The following is a description of a gene set: Human Gene Set: GSE25123_CTRL_VS_IL4_AND_ROSIGLITAZONE_STIM_MACROPHAGE_DN from publication Szanto A, Balint BL, Nagy ZS, Barta E, Dezso B, Pap A, Szeles L, Poliska S, Oros M, Evans RM, Barak Y, Schwabe J, Nagy L (PMID 21093321) Conditional macrophage-specific PPARg knockout mice were generated on C57Bl/6 background by breeding PPARg fl/- (one allele is floxed, the other is null) and lysozyme Cre transgenic mice. PPARg and IL-4 signaling was analyzed on bone marrow-derived macrophages. Bone marrow of 3 mice per group was isolated and differentiated to macrophages with M-CSF (20 ng/ml). 20 ng/ml IL-4 was used to induce alternative macrophage activation and 1 uM Rosiglitazone (RSG) was used to activate PPARg. From each mouse 4 samples were generated: 1. M-CSF, 2. M-CSF+RSG, 3. IL-4 and 4. IL-4+RSG. All compounds were added throughout the whole differentiation process, and fresh media was added every other day. Control cells were treated with vehicle (DMSO:ethanol). After 10 days, RNA was isolated and gene expression profiles were analyzed using Mouse Genome 430 2.0 microarrays from Affymetrix. Genes down-regulated in wildtype bone marrow-derived macrophages: control versus IL4 and rosiglitazone. studied in species Homo sapiens, and this is the list of marker genes: SOCS2, MFAP3, DZIP3, MRPL33, KCNN2, GAPVD1, EIF2D, NDUFA12, CLCN3, FHIT, MCCC1, MED30, PITPNB, SLC1A2, CRYGS, NIPBL, NUDT7, MAP1A, RPS7, EEF1AKMT1, SNRNP25, ESD, MTF1, SLC35D2, NAV1, VAMP3, AGFG2, EMILIN2, CWC22, RRM2, RTL3, AMMECR1L (NCBI Gene Id 83607), TERB1, NDUFA2, MMUT, SAPCD1, PCDHB12, CLCA1, FXYD6, TMEM74, CAPN6, ZNF679, NDUFA13, CCAR1, CLMP, RPF2, GSX2, VIPAS39, RIC3, PSMA5, RPL31, NFIA, CCDC157, FAM241B, DEPP1, PAN3, USP53, EPHA7, EQTN, ESF1, RIMS3, MBNL2, MRPL20, ERCC6L2, NTMT1, ZNF292, CNOT6, DHTKD1, WT1, LRRC3B, GASK1B, EPHA6, UQCC6, GCFC2, NDUFB11, CYP11B1, MBOAT4, LMO3, POLR1D, KCNK7, MPZ, XRCC4, SLC22A17, PLPPR4, KGD4 (alpha-ketoglutarate dehydrogenase subunit 4), NAB1, HECTD2, CTNND2, GRIA2, PITPNC1, PRKACB, CCNE1, SPATA7, CLDN18, KALRN, SHH, SAMM50, CD28, PLOD2, FEN1, CA7, FRZB, CD302, MRPL55, MS4A18, NAA16, UBN2, ZNF536, EXOC6, PRELID1, SPMIP7, NDUFB2, RAD54B, TTC32, CLDN12, NOVA1, COMMD2 (NCBI Gene Id 51122), RPS14, CREB1, MAP2K4, SOHLH2, METTL2B, MYO1H, MSANTD1, FANCD2OS, KIAA1549L, PDE1C, SCRN3, RPL26, MARF1, INSYN2B, PTAFR, SRP19, SON, LAGE3, LPAR4, PSMB4, MBTD1, MICOS10, PNMT, MRPL11, SAPCD2, NDUFB3, ST18, MAP3K2, CDKL3, PRKACA, MYCBP2 (MYC binding protein 2), KLHL13, GABRA4, TBX15, CHRAC1, ASPRV1, TAOK3, CR1L, C3orf18, CCDC180, DUOXA2, URGCP (upregulator of cell proliferation), FOXP1, PROCA1, PPP1R3A, CHODL, RALY, GM2A, F8A1, ASTN2, SYNJ2BP, KHDC1L, ATP2B3, MMP16, GREM2, CIR1, DNAI2, URI1, LAMTOR5, C2CD5, DNAJB14, STEEP1, IRX5, AIF1L, GABRB3, TCEAL1, CYP2S1, LARGE1, CSDC2, TMPRSS2, FIBIN, POU5F2, MBD5, CSNK2A2, CXCL13, DDX3X, STIMATE, SNW1, MGA (NCBI Gene Id 84130), ATXN7L3B, WASHC4, COX7A2, AIRN (antisense of IGF2R non-protein coding RNA)